The following is a description of a gene set: Mouse Gene Set: GOMF_NADPH_DEHYDROGENASE_ACTIVITY Catalysis of the reaction: NADPH + H+ + acceptor = NADP+ + reduced acceptor. species: Mus musculus, and this is the list of marker genes: Adh4, Nqo1, Cbr4, Rtn4ip1, Cryz, Cbr3